The following is a description of a gene set: studied in species Homo sapiens from publication Chen Y, Wang X (PMID 31504780) Genes predicted to be targets of miRBase v22 microRNA hsa-miR-3171 in miRDB v6.0 with MirTarget v4 prediction scores > 80 (high confidence targets). Human Gene Set: MIR3171, and this is the list of marker genes: NEMF, SHC1, PSMD14, SMARCAD1, GUCY1A2, YME1L1, MIER3, ZNF678, PHKB, TACR1, STAU2, F13A1, GABRA4, OSBPL8, CNR1, ZNF292, PPIL3, F8, ST7L, PNO1, ZNF566, ZNF268, GPR6 (NCBI Gene Id 2830), JADE1, PRDX6, KAT6A, NDUFS4 (NCBI Gene Id 4724), EYA1, THSD7B, PLA2G4A, IRF4, POLK, PNPLA3, PLAAT5 (NCBI Gene Id 120669), ITIH2, STXBP5, SOX6, SERPINB10, PHF12, AASDH, ZNF133, ECM2, RLF, ZNF714, FANK1, ADGRF1, ESPL1, UNC80, OIP5, PLAAT3, TRIQK, UBR5, LOX (NCBI Gene Id 4015), PIGM, FOXN3 (NCBI Gene Id 654111), PPP6R3, LATS2, G3BP2, NCAPH, MAPK6, LTBP3, TSPAN32, RGS18, LHFPL3, MTX3, LRP11, MEAF6, MED12L, FBXO33, ZKSCAN4, SET, TRAPPC10, HAVCR1, RNF138, SPATA1, TAFA2, PCDH10